The following is a description of a gene set: species: Homo sapiens Human Gene Set: GOMF_HYDROLASE_ACTIVITY_HYDROLYZING_O_GLYCOSYL_COMPOUNDS Catalysis of the hydrolysis of any O-glycosyl bond., and this is the list of marker genes: CEMIP, ADPRS, NEU2, ABHD10, SPACA5, GM2A, HPSE2, OGA, CHIT1, KLB, MAN2B2, NAGLU, MANEAL, MAN2A2, MAN2C1, HEXA, OTOG, LYG2, KL, OTOGL, HYAL4, MAN1B1, HEXB, GLB1L, GLA, GBA2, GLB1, CHI3L1, EDEM2, EDEM3, GUSB, AGL, LYZL4, SPACA5B, AMY1C, SPACA3, SI, LYZL2, MAN2A1, LYZL1, AMY2B, PARG, MAN1A2, MAN1C1, GANC, HYAL2, CHIA, PGGHG, LCTL, MAN2B1, MOGS, MANBA, GALC, AMY1A, MGAM2, CHI3L2, LALBA, NEU1, NEU4, GAA, CTBS, GBE1 (NCBI Gene Id 2632), SPAM1, IDUA, AMY2A, MANEA, HYAL3, LYZL6, NAGA, OVGP1, GBA3, NAGPA, MGAM, MYORG, GLB1L3, EDEM1, FUCA2, LCT, MAN1A1, GANAB, CEMIP2, HYAL1, TREH, GLB1L2, HEXD, ENGASE, HPSE, LYG1, AMY1B, FUCA1 (alpha-L-fucosidase 1), LYZ, GBA1 (glucosylceramidase beta 1), NEU3 (neuraminidase 3), GNE